The following is a description of a gene set: studied in species Mus musculus Mouse Gene Set: GOBP_RESPONSE_TO_STEROL_DEPLETION Any process that results in a change in state or activity of a cell or an organism (in terms of movement, secretion, enzyme production, gene expression, etc.) as a result of a stimulus indicating deprivation of sterols. Sterols are a group of steroids characterized by the presence of one or more hydroxyl groups and a hydrocarbon side-chain in the molecule., and this is the list of marker genes: Insig2, Srebf2 (sterol regulatory element binding factor 2, NCBI Gene Id 20788), Tmed2, Lyn, Pip4p1, Spring1, Erlin2, Amfr, Eif2a, Paqr3, Erlin1, Eif2ak3, Scap, Insig1, Npc1l1, Zbtb7b, Arhgef10l (NCBI Gene Id 72754), Srebf1